Given this list of marker genes Lep, Cers1, Sh2b2, Pid1, Sirt6, Stxbp3, Rhoq, Enpp1, Tnf, Grb10, Grk2, Ostn, Myc, Esr1, Upk3b, Ahi1, Prkca, Appl2, Ace, Pea15a (proliferation and apoptosis adaptor protein 15A), Gsk3a, here is a description of the gene set: Any process that stops, prevents, or reduces the frequency, rate or extent of the import of the hexose monosaccharide glucose into a cell or organelle. Mouse Gene Set: GOBP_NEGATIVE_REGULATION_OF_D_GLUCOSE_IMPORT species: Mus musculus